Given this list of marker genes CA11, CD302, TRPS1, OSBPL11, RIN2, KDM7A, ALG9, ACAA2, ARHGEF40, SOCS5, CORO1A, BLTP2, OSBPL1A, RXRA, PRKACB, CCDC69, FAM98A (NCBI Gene Id 25940), CPNE3, CH25H, SLC19A2, TMEM59, FRAT2, SCRN1, KCTD12, FGL2, CD47, ATP5MC3, RCOR1, CDIPT, MAP3K5, BLNK, ACAT1, SLC7A8, SOD1, HS2ST1, SLC9A6, MFSD1, RAB1A, CEBPD, DDX39B, ZNF468, HCK, RETREG2, TPST2, SSR1, RREB1, TGFBR2, RNASE6, EMP1, DNMT1, ECHS1, MAN2A1, FPR3, PDLIM2, CD36, ATIC, ACADM, CASP8, GCA, SLC38A6, ADIPOR1, TBC1D31, FBXL5, EVL, SPG21, SLA, TMX2, PDIA4, DUSP6, TGFBI, FN3KRP, TTC3, ADORA2B, PTBP1, PGRMC1, NIPA2, CLIC1, COIL, MRTFB, SRPRB, STAC, HOXB2, MPRIP, CSF1R, GATM, ENOSF1, SDHB, CSNK2B, GPD1L, EPAS1, ZNF331, TPP1, SFXN3, NAIP, SYNC, RNASE4, TMED10, PSTPIP1, KIF16B, PTPRE, DENND4C, KHNYN, TPK1, HACD1, NFYB (nuclear transcription factor Y subunit beta), HCAR3, SKAP2, CCDC86, SRSF9, REXO2, MRPL58, ARHGEF3, PCCB, APOBR, ARL5A, ADCY7, CHPT1, RHEB, MYCL, DENND4B, NDUFB2, SLC25A36, NAA40, REEP5, CD69, PRNP, LAPTM4A, PRPS2, WDR12, ARPC5, TLR2 (NCBI Gene Id 7097), FZD2, RAB7A, GEMIN6, CALM1 (NCBI Gene Id 801), TMEM243, TNFSF10, NFE2, PICALM, CAPRIN2, LPP, IFT27, NPC2, PCYOX1L, WSB1, OAT, HLTF, CYTH4 (cytohesin 4), IL1R2, ZBTB1, ARFGAP3, CPQ, BLVRB, GET1, SPR, UQCRC1, CASP1, DPEP2, IL27RA, ABHD10, NDRG3, LGALS8, ARMCX3, SAMHD1, IQGAP2, CYP1B1, TMEM70, PRIM1, MYC, MBP (NCBI Gene Id 4155), SEPTIN9, SNX5, C11orf21, IFITM2, GMFG, GYG1 (NCBI Gene Id 2992), PYCARD, IFI16, LBR, TULP3, RAB31, NCSTN, KLHL26, MOB3B, MLEC, EIF4G3, SYK, GMCL1, HSPA6, SLC12A7, FES, CHMP2A, GAR1, ARHGAP19, MLXIP, PPT1, AP3D1, CRTC3, here is a description of the gene set: species: Homo sapiens Human Gene Set: GSE45365_NK_CELL_VS_CD8_TCELL_MCMV_INFECTION_UP Murine Cytomegalovirus (MCMV) infection leads to early activation of various immune cells, including B and T lymphocytes, before the actual initiation of antigen-specific adaptive immunity. This activation is partly driven by innate cytokines, including type I interferon (IFN), which are induced early after infection. The objective of this study was to address the role of type I IFN in shaping early/innate B and T cell responses to a primary acute viral infection. In order to decipher the specific impact of IFN-I on cell subsets, we performed a genome-wide expression analysis on WT splenic B and CD8 T lymphocytes isolated from C57BL/6 mixed bone marrow chimera mice. This study complements series GSE39555, which focused on early responses of NK cells and of the two subsets of conventional dendritic cells. Genes up-regulated during primary acute viral infection: NK vells versus CD8 T cells.